The following is a description of a gene set: Human Gene Set: KEGG_MEDICUS_PATHOGEN_KSHV_K15_TO_TNF_NFKB_SIGNALING_PATHWAY studied in species Homo sapiens Pathway Definition from KEGG: K15 -> TRAF2 -> TAK1 -> IKK -> NFKBIA -> NFKB KSHV K15 to TNF-NFKB signaling pathway. Pathway ID: N00173. Pathway type: Pathogen. Pathway class: nt06516 TNF signaling., and this is the list of marker genes: RELA, MAP3K7, IKBKB, IKBKG, NFKB1, CHUK, NFKBIA, TRAF2 (TNF receptor associated factor 2)